Given this list of marker genes MRE11, PRKDC, FH, PNKP, WAS, DEK, USP51, ACTR2 (NCBI Gene Id 10097), MAD2L2, CYREN, SMCHD1, TOP2B, NSD2, POT1, KMT5C, RIF1, SHLD3, HMGA2, PARP3, MRNIP (MRN complex interacting protein), SHLD1, ERCC6, KDM4D, AUNIP, KMT5B, WRAP53, SETMAR, NUDT16L1 (NCBI Gene Id 84309), TFIP11, SHLD2, HSF1, here is a description of the gene set: Any process that modulates the frequency, rate or extent of double-strand break repair via nonhomologous end joining. studied in species Homo sapiens Human Gene Set: GOBP_REGULATION_OF_DOUBLE_STRAND_BREAK_REPAIR_VIA_NONHOMOLOGOUS_END_JOINING